Given this list of marker genes TMEM108-AS1, RPS6KL1, ARPP21, SYBU, RYR2, GRID2, NRBP2, DOCK9, CELF2-AS1, ANO3, KCNH7-AS1, STX3, ADAM11, PNMA3, BICDL1, R3HDM1, ENSG00000291211, FADS3, PLXNA3, ERICH3, CELF2-AS2, SYNE1, SCN2A, PTPRK, ARFGEF3, CAND2, DGKH, SLC4A10, CSMD1, SLC27A1, PTCH2, PCLO, SEC31B, SLC8A3, GRB14, ANKRD36B, ACTN2 (actinin alpha 2), GNB3, JAKMIP3, HYDIN (HYDIN axonemal central pair apparatus protein), SPEG, LINC00342, PROM1, CACNA1A, TIMP3, SERPINB9, TSBP1, SRRM3, EPHA7, SGSM1, SPTBN4, CACNA1B, SNX32, NPY1R, LINC01873, GABRB1, PTPRD-AS1, UACA, CACNA1I, SLC2A13, ABCC8, NALF1-IT1, SLC7A5P2, FBN3, RGS11, PPFIA4, MYO1C, SLC26A4, USP32P2, CNTN3, CACNA1E, LINC00504, POU2F2, PI4KAP2, TMEM178A, PLEC, RAP1GAP2, LINC01410, SHISA9, ITPR1, SLC8A1-AS1, MYLIP, EXD3, PFKP, ABCA5, DLGAP2, CCDC144BP, HIC2, DYNC2I1, PRICKLE2-AS3, PNCK, ANKRD36, PTCHD4, ACAP3, STX1A, KLHL3, RAP1GAP, STK36, DNAJB2, CSGALNACT1, EEF2K, PKD1, TSPOAP1, LAMA5, RNF207, NTRK3, GDA, JAG2, ACADVL, NIN, KHDRBS2 (NCBI Gene Id 202559), FOXK1, DMWD, GRP, PGM5P2, RNF213, GOLGA8A, ANKRD18A, LRRIQ1, TMEM74B, ELMOD1 (NCBI Gene Id 648653), GOLGA8B, FBXW7, PDZD2, TNK2, RASGRP2, ENSG00000237654, SAMD5, PPFIBP1, CACNA1G, KCNQ1OT1, RAPGEFL1, PLEKHA6, CSMD2, CC2D1A, CACNA1C, KIF1C, KCNMA1, LIMS2, TARBP1, IGSF21, DAB2, DUSP5P1, KIRREL3-AS2, FGF17, AHI1, LINC00506, MMP17, DNM3OS, RYR3, MYO6, RPL23AP32, SCN9A, GULP1, PTPN13, LMO7, CPNE7, AP1G2, PDIA2, LRRC4C, MST1, MIAT, FAM227A, CELF2, LGI4, LTBP4, here is a description of the gene set: from publication Fan X, Dong J, Zhong S, Wei Y, Wu Q, Yan L, Yong J, Sun L, Wang X, Zhao Y, Wang W, Yan J, Wang X, Qiao J, Tang F (PMID 29867213) species: Homo sapiens Human Gene Set: FAN_EMBRYONIC_CTX_EX_4_EXCITATORY_NEURON